The following is a description of a gene set: Goals/objectives: to identify various gene expression in B cell subsets derived from human PBMC and cord blood Genes down-regulated in B lymphocytes: memory versus naïve. studied in species Homo sapiens from publication Suryani S, Fulcher DA, Santner-Nanan B, Nanan R, Wong M, Shaw PJ, Gibson J, Williams A, Tangye SG (PMID 19965666) Human Gene Set: GSE17186_MEMORY_VS_NAIVE_BCELL_DN, and this is the list of marker genes: APAF1, TIAM1, RNPEP, SPC24 (NCBI Gene Id 147841), RAD54L, KCNIP3, PTMS, HGFAC, AKR7A2, PRKAR2A, AQR, IQGAP3, RAB29 (RAB29, member RAS oncogene family), CDC42EP3, SLC7A7, ZFAND4, ACE, ZNF623, H1-0, UBAC2, MYBL2, RAB43, GPN1, CENPN, DDX60, LIPA, HSD3B7, LTBR, ZNF467, DYM (dymeclin), TCIRG1, NRROS, NRBF2, ARPC2, LACTB, TUBB6, RASGRF2, ATP8B4, ADORA2B, LRRC40, SLA, EML5, GOLIM4, GPR4, RRAS, CEBPD, HLA-DRB1, SEPTIN10, BACH1, SLC25A25, ASXL1, DAPP1, TP53I13, DEGS1, FAM149A, MAP2K6, LIPE, CAMKMT, TMBIM1, SLC27A2, KIFAP3, UXS1, SLCO5A1, CHEK2, AURKA, WSB2, BIN3, ITM2B, ZNF414, GEMIN8, HSPB6 (NCBI Gene Id 126393), DIAPH2, ATP6V1D, ALS2CL, PHETA2, RAB37, ARHGEF6, SKIC3, KIF23, ZNF22, RGS1, VPS35, DLGAP4, DIPK2A, CD80, COPZ1, SLC25A11, WDFY2, SIGLEC7, POMP, DBF4, LUZP1, STAG3, S100PBP, ARHGAP22, ATG4C, ZNF516, MXD3, RCC1, SOAT2, NDUFA8 (NCBI Gene Id 4702), SGSM2, RCAN1, MAP2K3, VRK2, NADK2, NR2C2AP, SEPHS1, DSCAM, XIAP, SLC25A24, SSR1, CEP290, FAM89B, TKT, FCGR3A, PREB, TMCC2, SMAD1, SIPA1L3, MOB1A, MKRN1, SMC2, CHD9, BLOC1S2, ATP6AP2, ZNRF1, CLINT1 (clathrin interactor 1), SERPINB2, RNF135, ARID4A, SMIM3, CA9, ABHD15, ACTG1, IL7R, TRIM36, RAC1, ENTPD1, KPNA4, CSGALNACT2, KPTN, ATAD2, NDUFAF7, KRT80, ACSL1, ZNF263, TAX1BP3, TRIQK, NDST1, RAP2B, TGFBR1, CRYBG3, KMO, ZNF600, SCP2, COL23A1, NCAPD3, ZBTB42, ESPL1, SESN2, FBXO10, MAPK7, RUNDC3B (RUN domain containing 3B), B4GALT4, IL12RB2, RTN4, RBL1, CEP83, TNFRSF11A, CDKN2B, NOSTRIN, VHL, TMEM170B, KANK3, ATF3, IFNAR2, TMEM131L, G3BP1, ANKRD50, FNBP1L, PRC1, MYO5A, HLA-DOA, DPP4, ATP6V0C, TUBA1B, SPINT1, NAPSA, LGALS3, LSP1, NEURL1B, ELK3, TBKBP1, FAM217B, ARHGAP6, TUSC1, FAM98C, C4orf46, LTBP2